Given this list of marker genes Kcnj5, Gng10, Gnb2, Adcy5, Gngt2, Gnai1, Gng3, Gnb5, Adcy8, Gng4, Kcnj3, Gngt1, Adcy7, Gnb3, Gng11, Kcnj2, Gnat3, Gabbr1, Gng7, Gng8, Kcnj12, Gng5, Kcnj10, here is a description of the gene set: studied in species Mus musculus This event has been computationally inferred from an event that has been demonstrated in another species.<p>The inference is based on the homology mapping from PANTHER. Briefly, reactions for which all involved PhysicalEntities (in input, output and catalyst) have a mapped orthologue/paralogue (for complexes at least 75% of components must have a mapping) are inferred to the other species. Reactome Pathway: GABA B receptor activation electronically inferred by orthology from the curated human pathway part of: GABA receptor activation